Given this list of marker genes MIR199B, FGF9, DNMT1, MYOCD, OLFM2, SOD2, MIR1-1, MIR145, MIR18A, EHMT2, MIR182, MIR143, MIR221, MIR214, MIR140, MIR21, PDGFB, here is a description of the gene set: species: Homo sapiens Human Gene Set: GOBP_PHENOTYPIC_SWITCHING A reversible switch of a cell from one cell type or form to another, at a frequency above the expected frequency for somatic mutations. Phenotypic switching involves changes in cell morphology and altered gene expression patterns. For example, Candida albicans switches from white cells to opaque cells for sexual mating. Phenotypic switching also occurs in multicellular organisms; smooth muscle cells (SMCs) exhibit phenotypic transitions to allow rapid adaption to fluctuating environmental cues.